Given this list of marker genes Fgf8, Phb1, Dnm2, Rgs8, Gper1, Mrap2, Slit2, Rock2, Usp33 (NCBI Gene Id 99490), Kctd16, Pdcl, Pde3a, Aplnr, Alk, Ada, Rgs14, Becn2, Rgs4, Itgb3, Rnf113a1, Rpgrip1l, Ubqln2, Rph3al, Frmpd1, Kctd12, Gipr, Pde6h, Adm, Rgs13, Vps35, Arrb2, Pde10a, Prmt5, Rock1, Adrb2, Slit3 (slit guidance ligand 3), Mgrn1, Aipl1, Rgs12, Rgs18, Rgs10, Tmod2, Abhd6, Pde4a, Rack1, Klk14, Prkca, Padi2, Klk5, Camk2a, Met, Git2, Ywhab, Cav2, Kctd8, Rnf113a2, Ramp2 (receptor (calcitonin) activity modifying protein 2), Necab2, Gpsm1, Aplp1, Rgs7, Apela, Trem2, Grm5, Edn1, Rgs11, Atp2b4, Zdhhc25, Ppp1r9b, Calcr, Drd2, Cry1, Mrap, Grk4, Arrdc3, Usp20, Git1, Chga, Pdc, Robo1, Ptgdr2, Sstr4, Grk5, Myh9, Nos1, Gpr27, App, Ric8a, Dgkq, Dtnbp1, Arrb1, Phf24, Gas2l2, Gnai2, Plek, Syp, Pde4d, Snca, Stmn1, Camk2b, Pde5a, Gpr158, Plcb1, Slc24a4, Pde6g, Pomc, Ptger3, Slc39a14, Inpp5a, Oprl1, Gsk3a, Itgb1, Drd3, Grp, Dnm1, Ramp1, C3 (complement component 3), Ramp3, Rgs6, Tulp3, Grk3, Ppp3ca, Dynlt1b, Rgs9 (regulator of G-protein signaling 9), Pde2a, Pld2, Ccl5, Gprasp1, F2, Crtc3, Ece1, Apln, Bicd1, Arr3, Adcyap1, Klk6, Zdhhc7, Hif1a, Grk1, Cntn2, Sag, Tub, Ly6g6e, Mgll, Ulk4, Rgs2, Homer2, Lrrk2, Palm, Zdhhc3 (NCBI Gene Id 78884), Adrb1, Grk2, Oprm1, Acp3 (NCBI Gene Id 77915), Grk6, Sh2b3, Kctd12b, here is a description of the gene set: studied in species Mus musculus Any process that modulates the frequency, rate or extent of G protein-coupled receptor signaling pathway. Mouse Gene Set: GOBP_REGULATION_OF_G_PROTEIN_COUPLED_RECEPTOR_SIGNALING_PATHWAY